Given this list of marker genes Pink1, Fbxo7, Gba1, Hk2, Stub1, Nod2, Slc25a5, Huwe1, Vps13d, Irgm2, Prkn (NCBI Gene Id 50873), Htt, Slc25a4, Igtp, Dele1, Atp5if1, Irgm1, Cdc37, Mul1, Ube2a, Cers1, Ambra1, Bnip3, Eif2ak1, Tomm7, Vdac1, Hdac6, here is a description of the gene set: Any process that activates or increases the frequency, rate or extent of mitochondrion degradation by autophagy. species: Mus musculus Mouse Gene Set: GOBP_POSITIVE_REGULATION_OF_AUTOPHAGY_OF_MITOCHONDRION